The following is a description of a gene set: from publication Chen Y, Wang X (PMID 31504780) Mouse Gene Set: MIR_208B_5P Genes predicted to be targets of miRBase v22 microRNA mmu_miR_208b_5p in miRDB v6.0 with MirTarget v4 prediction scores > 80 (high confidence targets). species: Mus musculus, and this is the list of marker genes: Jakmip3, Scgb2b7, Lcor, Timm8a1, Zfr, Scgb2b20, Suz12, Plpp3, Stag1, Znrf3, Lgr4, Rexo2, Taf7, Ppp3ca, Slc23a2, Akap6, Stxbp1, Creb1, Aoc3, Pcdh8, Pqbp1, Ttll7, Ube2d2a, Fzd2, Fcrla, Fbxo3, Cdr2, Cd207, Hic2, Cdh20, Apc, Unc80, Zfp704, Dip2a (NCBI Gene Id 78897), Mttp, Ccl25, Cripto, Scgb2b19, Ube2d2b, Hdac9, Pi15, Lrrc3b, Msi2, Abtb3, Paip2, Mcur1, Ralyl, Arl8b, Sfrp1, Aloxe3 (NCBI Gene Id 23801), Ptgis, Ston2, Alkal1, Ccnyl1, Dpy19l2, Slk, Ifit1bl2, Marchf4, Cul4a, Slc12a6, Ap5z1, Mxi1, Nt5dc3, Sirt1, Tmed10, Vdr, Med13l, 1700025G04Rik, Gls, Scgb2b17, Naa15, Ctr9, Adamts20, Csn3, Rab9b, Lhfpl3, Rnf38, Lrrc40 (NCBI Gene Id 99722), Vmn1r132, Tm9sf3, Cltc, Ctxn1, Nsd3, Lonrf1, Eif5, Ipo9, Adcy3, Adgra2, Slc7a5, Arhgef26, Pknox1, Naaladl2, Rnf11, Ube2b, Scgb2b12, Grik2, Ctnnd2, Cep170, Mfap3l, Map4k5, Semp2l2a, Il1rl1, Srsf6, Grp, Stx16, Cnmd, Ube2k, Nipbl, Tor1aip1, Nufip2, Adrb1, Cep97, Mef2a, Smc6, Maml3, Ro60, Stc1, Ccnj, Zc3h12a, Mtdh, Klhl24, Gabrg2, Pde7a, Scgb2b15, Zkscan16, Mdk, Ggnbp1, Tgfbr1 (transforming growth factor, beta receptor I), Tle3, Hoxc4, Tprg1l, Plekha7, Zfp36l1, Cdk19, Hnrnph2, Rnf111, Cdh2, Serp1, Zbtb16, Hmgn3, Scgb1b27, Grem2, Tmem170b, Aff4, Cenpk, Nog, Zbtb14, Smim10l1, Ufc1, Gnai3, Eef1b2, Trpc5, Katnal1, Gnrhr, Gsn, Me1, Ecm2, Gdnf (NCBI Gene Id 14573), Prdm6, Bdp1, Mtm1, Il6st, Map4, Chtop, Higd2a, T, Dclre1c (NCBI Gene Id 319261), Cep43 (NCBI Gene Id 75296), Ccdc141, Onecut2, Ing4, Srpk2, Tpst1, Csmd1, Cnot8, Btg3, Bnc1, Eif2b2, Nkrf